Given this list of marker genes MYBL2, NPM1, HSPD1, NOP2, TFAP2A, here is a description of the gene set: studied in species Homo sapiens Human Gene Set: REACTOME_TFAP2A_ACTS_AS_A_TRANSCRIPTIONAL_REPRESSOR_DURING_RETINOIC_ACID_INDUCED_CELL_DIFFERENTIATION TFAP2A acts as a transcriptional repressor during retinoic acid induced cell differentiation